The following is a description of a gene set: Reactome Pathway: Mineralocorticoid biosynthesis electronically inferred by orthology from the curated human pathway studied in species Mus musculus part of: Metabolism of steroid hormones This event has been computationally inferred from an event that has been demonstrated in another species.<p>The inference is based on the homology mapping from PANTHER. Briefly, reactions for which all involved PhysicalEntities (in input, output and catalyst) have a mapped orthologue/paralogue (for complexes at least 75% of components must have a mapping) are inferred to the other species., and this is the list of marker genes: Hsd3b9, Cga, Cyp11b2, Hsd3b4, Hsd3b2, Hsd3b8, Hsd3b5